The following is a description of a gene set: Human Gene Set: GOMF_PRENYLTRANSFERASE_ACTIVITY Catalysis of the transfer of a prenyl group from one compound (donor) to another (acceptor). studied in species Homo sapiens, and this is the list of marker genes: PGGT1B, NUS1, GGPS1 (geranylgeranyl diphosphate synthase 1), DHDDS, PTAR1, FNTB, RABGGTB, RABGGTA, CHM, FDPS, UBIAD1, PDSS2, FDFT1, COQ2, PDSS1, FNTA, COX10